The following is a description of a gene set: studied in species Mus musculus Any process that results in a change in state or activity of a cell or an organism (in terms of movement, secretion, enzyme production, gene expression, etc.) as a result of a carbohydrate stimulus. Mouse Gene Set: GOBP_RESPONSE_TO_CARBOHYDRATE, and this is the list of marker genes: Srebf1, Eif2b2, Trem2, Usf2, Adcy8, Sybu, Pdx1, Lrp5, Gjd3 (gap junction protein, delta 3), Cdt1, Hnf4a, Zfp36l1, Gprc6a, Ildr2, Ppara, C1qtnf12, Prkaa2, Rab11fip2, Map2k6, Tiam1, Mafa, Smarcb1, Prkca, Pde3b, Usf1, Col1a1, Twnk, Xbp1, Hnf1a, Gclc, Mir192, Slc26a6, Calcrl, Star (steroidogenic acute regulatory protein), Sarm1, Nptx1, Tra2b, Col6a2, Apoc3, Zbtb20, Cyp7a1, Ep300, Slc12a7, Txn2, Nkx2-2, Slc29a1, Plcb1, Tgfb1, Adcy5, Piwil4, Sod2, Mup1, Kat7, Hnf1b, Gpr27 (NCBI Gene Id 14761), Crhr2, Mir532, Prkce, Casr, Ucp2, Pim3, Rps6ka2, Map2k3, Gipr, Efna5, Eif2b4, Nfkb1, Gstp1, Adnp, Gria1, Raf1, Smad4 (SMAD family member 4, NCBI Gene Id 28063), Igf1r, Acvr2b, Cat, Pde4c, Sidt2, Ptprn, Pck2, Slc39a14, Sox4, Kcnj11 (potassium inwardly rectifying channel, subfamily J, member 11), Fbp1, Trh, Jagn1, Myh9, Foxa2, Pde8b, Pih1d1, Mir27a, Gck, Sri (NCBI Gene Id 73025), Kif5b, Pfkfb2, Vsnl1, Cftr, Egr1, Ndufaf2, Hif1a, Tjp1, Pax2, Ogt, Nadk, Lin28a, Ccl2, Foxo3, Prkn, Epha5, Endog, Ccdc186, Mup2, Slc9b2, Gper1, Mpc2, Fam3a, Pcsk1, Stx4a, Abcc8, Angpt2, Rps6kb1, Selenos, Apob, Osbp (oxysterol binding protein), Gpld1, Ptgs2, Ang2, Icam1, Mir379, Hmga1, Pde1c, Slc12a6, Gcg, Ptpmt1, Fto, Col4a3, Slc2a2, Elavl1, Rasal2, Naglu, Smad2, C2cd2l, Cdkn1b, Pck1, Cacna1e, Vamp2, Pla2g6, Oxt, Mir410, Rab34, Apoa2, Lepr, Nox4, Eny2, Fkbp1b, Mup4, Rab11fip5, Mup11, Tcf7l2, Hcfc1, Keap1, Ern1, Hmgcs2, Trpm5, Klf7, Myt1, Oprk1 (opioid receptor, kappa 1), Gjb6, Nr1h4, Ace, Brsk2, Baiap3, Agt, Casp3, Gpr39, Prkcb (protein kinase C, beta), Adipor2, Slc2a5, Atg7, Il1a, Thbs1, Smarca4, Sgcb, Ercc1, Guca2b, Abcg1 (ATP binding cassette subfamily G member 1), Sin3a, Nr1d1, Hid1, Ins1, Vcam1, Glp1r, Cltrn, Nr0b2, P2rx2, Prlh, Ptk2b, Acvr1c, Sirt1, Gas6, Ppard, Rptor, Mir320, Gja1, Nnat, Hmgn3, Ncf2, Camk2n1, Ppp3ca, Casp6, Cdk16, Rack1, Serpinf1, Crh, Mir130a, Rac1, Pfkl, Eif2b1, Mir369 (microRNA 369), Bad, Hmgcr, Cacna1d, Gys2, Nqo1, Rbm4, Tnf, Srf, Ptprn2, Grk2, Ctsl, Abca12, Ppp3cb, Gclm, Map2k4 (NCBI Gene Id 26398), Adipoq, Ucn3, Map4k4, Birc5, Arrb1, Eif2b5, Khk, Aacs, Slc30a8, Il1b, Lrp1, Pik3ca, Prkaa1, Igf1, Zbed3, Cpb2, Neurod1, Selenot, Stxbp4, Ncoa6, Trpm4, Kcnb1, P2rx3, Glul, Map1b, Kat5 (K(lysine) acetyltransferase 5), Eif2b3, Ghrl, Txnip, Lyn, Tbc1d1, Itga2, Irs2, Aqp4, Zbed6 (NCBI Gene Id 675760), Smad3, Gpam, Mup5, Mir200a, Trpa1, Lep, Mup3 (NCBI Gene Id 17842), Adra2a (NCBI Gene Id 11551), Prkaca, Extl3, Sesn2, Gpx1, Reg3g, Oxct1, Rab11b, Rfx6, Rmi1, Gpr82 (NCBI Gene Id 319200), Dynll1 (dynein light chain LC8-type 1), Ano1, Tunar, Ager, Gip, Unc13b, Gpr68, Mlxipl, Pax6, Mir337, Gckr, Th (NCBI Gene Id 21823), Mapk13